Given this list of marker genes ENG, RASA1, RYR1, EPHB4, CACNA1S, HBB, here is a description of the gene set: species: Homo sapiens High-output congestive heart failure Human Gene Set: HP_HIGH_OUTPUT_CONGESTIVE_HEART_FAILURE A form of heart failure characterized by elevated cardiac output. This may be seen in patients with heart failure and hyperthyroidism, anemia, pregnancy, arteriovenous fistulae, and others.